The following is a description of a gene set: part of: Cholesterol biosynthesis studied in species Mus musculus This event has been computationally inferred from an event that has been demonstrated in another species.<p>The inference is based on the homology mapping from PANTHER. Briefly, reactions for which all involved PhysicalEntities (in input, output and catalyst) have a mapped orthologue/paralogue (for complexes at least 75% of components must have a mapping) are inferred to the other species. electronically inferred by orthology from the curated human pathway Reactome Pathway: Cholesterol biosynthesis via desmosterol (Bloch pathway), and this is the list of marker genes: Dhcr7, Dhcr24, Lbr (lamin B receptor), Cyp51, Nsdhl, Tm7sf2